Given this list of marker genes Nbl1 (NCBI Gene Id 17965), Isy1, Tk2, Mtss1, Tfap2a, Rap1gds1, Zfp930, Cbx5, Phex (NCBI Gene Id 237149), Mpp1, Gpr68, Map3k21, Aldoc, Fam133b, Ube2r2, Msl2, Sos2, Pramel13, Prkar2a, Wipf3, Atf2, Ncbp1, Pigl, Mtus2, Slc6a8, here is a description of the gene set: from publication Chen Y, Wang X (PMID 31504780) Mouse Gene Set: MIR_138_1_3P Genes predicted to be targets of miRBase v22 microRNA mmu_miR_138_1_3p in miRDB v6.0 with MirTarget v4 prediction scores > 80 (high confidence targets). species: Mus musculus